The following is a description of a gene set: Mouse Gene Set: GOBP_REGULATION_OF_SISTER_CHROMATID_COHESION studied in species Mus musculus Any process that modulates the frequency, rate or extent of sister chromatid cohesion., and this is the list of marker genes: Wapl, Ddx11, Bub1, Naa10, Recql4, Axin2, Slf2, Sfpq, Sgo2a, Smc5, Tnks, Atrx, Nsmce2, Macroh2a1, Ctnnb1 (NCBI Gene Id 12387), Slf1, Fen1, Rad21